The following is a description of a gene set: CD4(+)Foxp3(+) regulatory T (Treg) cells originate primarily from thymic differentiation, but conversion of mature T lymphocytes to Foxp3 positivity can be elicited by several means, including in vitro activation in the presence of TGF-beta. Retinoic acid (RA) increases TGF-beta-induced expression of Foxp3, through unknown molecular mechanisms. We showed here that, rather than enhancing TGF-beta signaling directly in naive CD4(+) T cells, RA negatively regulated an accompanying population of CD4(+) T cells with a CD44(hi) memory and effector phenotype. These memory cells actively inhibited the TGF-beta-induced conversion of naive CD4(+) T cells through the synthesis of a set of cytokines (IL-4, IL-21, IFN-gamma) whose expression was coordinately curtailed by RA. This indirect effect was evident in vivo and required the expression of the RA receptor alpha. Thus, cytokine-producing CD44(hi) cells actively restrain TGF-beta-mediated Foxp3 expression in naive T cells, and this balance can be shifted or fine-tuned by RA. Human Gene Set: GSE13306_LAMINA_PROPRIA_VS_SPLEEN_TREG_UP species: Homo sapiens from publication Hill JA, Hall JA, Sun CM, Cai Q, Ghyselinck N, Chambon P, Belkaid Y, Mathis D, Benoist C (PMID 19006694) Genes up-regulated in comparison of CD4 T cells activated with lamina propria dendritic cells versus regulatory T cell (Treg)., and this is the list of marker genes: PBX3, MKNK2, HIPK3, SCIN, RB1CC1, IFT56, ICAM1 (intercellular adhesion molecule 1), BCL2L13, ZNF619, ITGAL, ZNF493, GRHL1, ELOA, DSG2, CYBA, C3orf80, SP2, ATRN, DOCK8, DOT1L, RARG, NIBAN1, UBLCP1, CCPG1, KIAA0040, CDK5R1, TMEM127, ZNF655, KIF5C, NFIX, GLCCI1, ATXN7 (ataxin 7), MON1A, UNC5CL, KAZN, SERINC3, ARHGAP30, IKZF4, LHFPL6, NLK, SMARCD1, DYRK2, ITGB3BP, LPGAT1, TRIP4, CREBRF, FRMD4B (FERM domain containing 4B), PPM1B, ZHX1, ASXL1, ALDH1A2, SHLD2 (shieldin complex subunit 2), TP53INP1, PON2, ERI2, HSD17B4, SLC9A8, INVS, MYLIP, RNF44, SESN3, ATP6AP2, MGAT1, TRAPPC2, ZDHHC2, EXT2, C16orf74, SPSB3, FKTN, TRIM56, ALG1, RNF150, CDC42SE2, MFAP1, FAM53B, GNMT, CARD6, SERINC5, LCLAT1, PGPEP1L, SLC44A1, PPP1R10, UPF1, CENPQ, KIF5B, LTF, SLC25A33 (NCBI Gene Id 84275), STX1A, TMBIM6, PPP1R3G, PARP12, C14orf28, GIMAP4, SPRYD3, MAPK8, ZDHHC15, SPACA1, DAZAP2, COQ10B, TLR1, CCDC88C, SNAPC5, NHSL2, ATP11C, OGA, KIF3B, GIMAP8, LASP1, UBE2Q1, PTPN1, BCAS1, S100A8 (S100 calcium binding protein A8), DGKQ, RBL1, REV3L, ADK, ANP32E, PCSK1, SGMS1, NSD1, HAPSTR1, VEZF1, QNG1, SCN5A, TNFSF4, REEP3, HIPK2, FBXL2, FAM120AOS, SLC35D1, AFF1, CREBL2, DGAT2, RFTN1, TPM3, FBXL3, DAO, STAM2, YPEL2, C16orf54, REP15, PRG4, CD70, BACH2, SMAD5 (SMAD family member 5), RGS2 (regulator of G protein signaling 2, NCBI Gene Id 5997), MLANA, TRAF4, MAP3K7, LIG4 (DNA ligase 4), BCO1, PTPRJ, SESN1, ZNF592, FMR1, TNRC6A, RBM48, STK10 (NCBI Gene Id 729035), PDE11A, MAP1LC3B (microtubule associated protein 1 light chain 3 beta), TOB1, CREB1, RABGAP1L, AMIGO2, CTDSP1, PCED1B, STAC3, CNTD1, CAAP1, ZBTB11-AS1, EPC2, PINX1 (NCBI Gene Id 91819), BCAS3, MED15, KLF17, KAT5, TRAM2, CREBBP, ITM2C, PTPRA, FAM107B, TMEM216 (transmembrane protein 216), ERBIN, GPR174, LMBRD1, CD83, PLAGL1, PAPOLG, PRKAG1, TIGAR, TAGAP, PCIF1 (NCBI Gene Id 63935), BTNL9, PLCL1, ANKRD12, FAM3B, SPIN1, ARHGAP1, DUSP4